The following is a description of a gene set: species: Homo sapiens In the present study we used Affymetrix oligonucleotide microarrays to produce gene transcription profiles for the major leukocyte types in humans. This comprehensive dataset enabled us to not only establish which genes were expressed in each leukocyte type, but also which genes were expressed in each subset after activation. The used of a comprehensive dataset of gene profiles from all the major human leukocyte subsets enabled a novel and powerful means for identification of genes associated with single leukocyte subsets, or different immune paradigms. Human Gene Set: GSE3982_BASOPHIL_VS_TH2_DN from publication Jeffrey KL, Brummer T, Rolph MS, Liu SM, Callejas NA, Grumont RJ, Gillieron C, Mackay F, Grey S, Camps M, Rommel C, Gerondakis SD, Mackay CR (PMID 16474395) Genes down-regulated in comparison of basophils versus Th2 cells., and this is the list of marker genes: GGH, MRTO4, NUSAP1, TMED3, ELOVL6, SPATS2, IGFLR1, MAGI1, SDC4, WIZ, TP53, MCUR1, TTF1, PLA2G4A (NCBI Gene Id 5321), HGH1, SLN, MRPL39, SLAMF1, HOOK2, PSD4, VBP1, LUC7L2, PSMC4, MRPL57, HIRIP3, PFAS, SHARPIN, MFHAS1, LTBP2, NDUFA8, WDR18, SH2D1A, ABCF2, HACD3, RNASEL, DNAJB12, DOHH, SIGMAR1, CHMP6, AHI1, EEF2, TEX10, NCBP1, MAGOH2P, PTPN11, SYTL2, MOSPD1, HAUS5, ADCK2, POLR2E, AARS1, MSH2, ITGB3BP, CENPQ, RPS19, RRM1, RXYLT1, MAVS, RRP7A, APEX1, SLC25A32, RPUSD2, COL10A1, HMG20A, WDR46, TOMM34, IL2RA, WNT16, TP63, ILF3, OR7E36P, CTSH, PHLDA1, PLA2G2F, INPP4B, PSMB2, TOP3A, HSPD1, EIF4E, PLEKHG6, HYOU1, P3H1, GPR171, HDHD5, CALB2, QDPR, MRPL42, DIXDC1, CLDN6, PHB1, ACTL6A, OTULINL, PPIF, ERCC6, OLA1, SMPX, FASLG, CDC123, PFDN4, TTF2, LRRC42, PSMB5, CHSY1, BANF1, CXCR6 (C-X-C motif chemokine receptor 6), PPARG (peroxisome proliferator activated receptor gamma), ORC2, CPLANE2, MCTS1, MTHFD1, LSM6, SERBP1, ADRM1, SCNN1G, DPP4, ERF, VARS1, PROM1 (prominin 1), MED24, CSTF2T, TUSC2, SNUPN (snurportin 1), RARB, SEC14L2, PRSS50, ESPL1 (NCBI Gene Id 9700), ENO1, TOMM40, SNRPE, PPT1, LRRC8D, EIF4A1, EIF5A, SORT1, TMEM223, GPN2, PER2, CLIC4, ENDOD1, RNF8, RPA3, EMC1, DBT, USP13, IARS1, GLRX2, CBS, CKS2, XPO1, BCS1L, OGFOD3, SMIM7, SLC41A3, MCCC2, DNAI1, PARK7, MTNAP1, GLRX3, PXMP2, EIF3J, PSMD7, ZNF551, TIPIN, HIBCH, TMEM8B, DCUN1D4, ATP10A, RIC8B, HNRNPF, E2F4, NUP37, BLM, SPAG5, GEMIN4, RSRC1, ORC6, MRPL11 (mitochondrial ribosomal protein L11), NLRP2, POLR2C, TIAM1, RCC1L, DCPS, RAP1GDS1, KCNK1, ZAP70, MRPL4, SDHC, FOCAD, LAIR2, LCK, AURKA (NCBI Gene Id 8465), CPN2, MTG1, FASTKD1, CAD, SPA17, CSE1L, CKAP2